Given this list of marker genes LRCH3, CASD1, PLXNB2, PPTC7, ZFYVE9, BTLA, KIF16B, ARHGAP35, HSD17B8, RAP1GDS1, CPM, PELI1, PAQR9, SBF2, AANAT, SNRK, RPL31, TOM1L2, IL24, PPP1R9B, URB2, PPP1R3B, DUSP10, SNX19, DMRTA1, PTCRA, BLK, FBXW4, AATF, RAB20, CLMN, KLC2 (NCBI Gene Id 64837), POLR3E, FAU, PPAN, NRXN1, ITPKC, AKAP11, CALCRL, ARMC7 (armadillo repeat containing 7), TOP1MT, EEF2K, TIMP2 (NCBI Gene Id 7077), HIPK1, BEND4, LZTFL1, IL21R, NALF1 (NCBI Gene Id 731895), NFE2L1, ABCG1, AQP9, LRIG2, HDHD5, THEMIS2, DNAJA3, ZMYM2, LYL1, KCNK4, GPR173 (NCBI Gene Id 54328), PRMT3, MPPE1, FRMD4B, MORC3, SLC18A2, SP2, MUC6, CLCN1, CSNK1E, KLK8, TAF4B, TLR9, KLHL18, ARHGAP39, MGAT5, ZDHHC13, LPAR4, CYTH4, SH3BGRL2, KCNH2, PAX5, NAA30, NFE2L2, TMEM182, TBC1D2B, CCR3, AGL, SYDE2, SH3GL1, SS18L1, KPNA4, BCAR3, ACVRL1, POU6F1, FAM78A, PRDM15, RASAL1, SYNRG, NOMO1 (NODAL modulator 1), ADGRG5, SLC25A26, ZMYM5, CDX2, TM9SF4, CELSR1, MBTPS1, EXOC6B, ZFYVE27, IL17A, MIR29A, TRIM65, ACTR1B, RLF, SLC45A2, CD2AP, PDGFB, MOB3C, CREBL2, TMEM42, STRA6, C2CD4A, TULP3, MEF2D, PLCG2, MERTK, ERO1B, PADI2, HEATR5B, PARP3, CASP8, ZBTB24, STX2, GRK6, CLCF1, ULK3, ALPK3, FBXO28, SH3BP5, TDRKH, EXD2, NR3C1, TTC7A, SLC27A6, PTPRF, MYO9A, TNFRSF25, MTTP, LBH, PLA2G4F (NCBI Gene Id 255189), RIPOR2, POLR1A, SUN2, here is a description of the gene set: Human Gene Set: GSE4984_UNTREATED_VS_LPS_TREATED_DC_UP Human monocyte derived dendritic cells matured via galectin-1 or LPS. species: Homo sapiens Genes up-regulated in monocyte-derived dendritic cells: control versus LPS. from publication Fulcher JA, Hashimi ST, Levroney EL, Pang M, Gurney KB, Baum LG, Lee B (PMID 16785517)